Given this list of marker genes Htr7, Odaph, Kalrn, Bcar3, Srsf1, 9330159F19Rik, Ankub1, Tmem260, Pten, Klf10, Rnf111, Wee2, Selenot, Pja2 (NCBI Gene Id 224938), Lrrc39, Zfp991, Gjb1, Sfrp4, Arid4b, Rabgap1, Zfp110, Ankrd33b, St8sia5, Tob1, Tubd1, Suds3, Prkg1, T2, Fbxo28, Dld, Plagl2, Wbp11, Zfp445, Crim1, Dbf4 (DBF4 zinc finger), Naa15, Zfp992, Acsl3, Grip1, Pdcd6ip, Opcml, Dido1, Metap2, Rasl11b, Ppp1r3f, Snrnp27, here is a description of the gene set: from publication Chen Y, Wang X (PMID 31504780) species: Mus musculus Mouse Gene Set: MIR_7237_3P Genes predicted to be targets of miRBase v22 microRNA mmu_miR_7237_3p in miRDB v6.0 with MirTarget v4 prediction scores > 80 (high confidence targets).